Given this list of marker genes Hspa1a, Ppp1r15a, Klf6, Jun, Pik3ip1, Fos, Tra2a, Junb, Tsc22d3, Hspa1b, Jund, Btg2, here is a description of the gene set: Genes negatively differentially expressed in cell type: CD4+ T cell upon treatment with cytokine: IL-17D in mouse lymph nodes in vivo. Cytokines mediate cell-cell communication in the immune system and represent important therapeutic targets. A myriad of studies have highlighted their central role in immune function, yet we lack a global view of the cellular responses of each immune cell type to each cytokine. To address this gap, the authors created the Immune Dictionary, a compendium of single-cell transcriptomic profiles of more than 17 immune cell types in response to each of 86 cytokines (>1,400 cytokine-cell type combinations) in mouse lymph nodes in vivo. A cytokine-centric view of the dictionary revealed that most cytokines induce highly cell-type-specific responses. For example, the inflammatory cytokine interleukin-1β induces distinct gene programmes in almost every cell type. A cell-type-centric view of the dictionary identified more than 66 cytokine-driven cellular polarization states across immune cell types, including previously uncharacterized states such as an interleukin-18-induced polyfunctional natural killer cell state. from publication Cui A, Huang T, Li S, Ma A, Pérez JL, Sander C, Keskin DB, Wu CJ, Fraenkel E, Hacohen N (PMID 38057668) Mouse Gene Set: CUI_T_CELL_CD4_IL17D_RESPONSE_DN species: Mus musculus